The following is a description of a gene set: species: Homo sapiens Human Gene Set: GOBP_ENDOSOME_TO_LYSOSOME_TRANSPORT_VIA_MULTIVESICULAR_BODY_SORTING_PATHWAY The directed movement of substances from endosomes to lysosomes by a pathway in which molecules are sorted into multivesicular bodies, which then fuse with the lysosome., and this is the list of marker genes: RUFY4, MVB12A, CHMP4A, CHMP6, CHMP1B, CHMP3, VPS4B, UBXN6, CHMP4C, CHMP7, CHMP5, VPS4A (vacuolar protein sorting 4 homolog A), VCP (valosin containing protein), LYST, CHMP2A, CHMP2B, CHMP1A, CHMP4B